Given this list of marker genes RIMS4, CNOT7, FOXI2, RFX7, INSC, TMEM80, CAMK2D, WBP4, XCL2, UBQLN3, USP35, IGSF10, HDAC9, EDDM3A, RASAL2, MPV17, MYH11, NR4A3, DIPK1A, BCL11A, BLZF1, ZC2HC1B, CCDC28A-AS1, QRICH1, SCN9A, SLC36A1, ZNF417, RSPO4 (NCBI Gene Id 343637), CLSPN, SIAH1, USP9X, DLAT, VKORC1, CNNM1, here is a description of the gene set: species: Homo sapiens Genes predicted to be targets of miRBase v22 microRNA hsa-miR-6772-5p in miRDB v6.0 with MirTarget v4 prediction scores > 80 (high confidence targets). from publication Chen Y, Wang X (PMID 31504780) Human Gene Set: MIR6772_5P